The following is a description of a gene set: studied in species Homo sapiens Any process that results in a change in state or activity of a cell or an organism (in terms of movement, secretion, enzyme production, gene expression, etc.) as a result of an interleukin-2 stimulus. Human Gene Set: GOBP_RESPONSE_TO_INTERLEUKIN_2, and this is the list of marker genes: IL2RA, IL2RG, IL2RB, STAT3, STAT5B, JAK3, CITED1, IL2, PTPN2, JAK1, STAT5A